Given this list of marker genes NFIL3, RAB5IF, MXRA7 (matrix remodeling associated 7), PDGFD, IRF8, ARSA, RNF8, FES, STAB2, KCTD5, LAIR2, HLA-DPB1, PSMD10, C5AR1, URGCP, PMS2P5, CEACAM7, PECAM1, VCL, DHX8, CHST15, UQCRFS1, LPCAT1, MGAM, NDUFA9, TGFBR3, TM6SF1, ACOT8, CTSO, RASL10A, UNC45A, DGKD, TMED1, GZMA, REXO4, RAB7A, ARTN (NCBI Gene Id 9048), PSTPIP1, ENPP4, CD38, TPI1, TMEM53, MAGED1, TMT1A, PHACTR4, DGLUCY, RAB38, FGD6, PTPRE, TST, MKLN1, TFF3, ADAMTS1, NFKBIL1, TMEM11, B3GAT1, GRHL2, ZNF804A, SPRED2, LAT2, ZDHHC4, CALU, ADGRA3, IFITM2, CLPB, CD8A, BLCAP, NPL, FBXO7, MAPKAPK3, TSPAN3, GALNT10, AKR1C3, CYTH4, KLRK1, PLEKHF1, MAP1S, KLHL4, LYZ, H2AC4, SUSD6, IFNA21, CEBPA, NDUFS6, RAB11FIP1, NOL10, CD63, ZNF142, PLAAT2, TTR (transthyretin), NKIRAS2, DRAM1, MOS, FEZ1, CSF1R, CAT, MT4, COQ2, ENC1, DNAI1 (NCBI Gene Id 3393), WASF2, AIF1, TARP, CRY2, JAK1, PLAC8, RNF14, TCTA, CEBPD, PLEK, ARHGAP26, PTPN12, LDLR, ZNF574, RHBDF2, NUDT11, TMEM147, THOC5, RHOQ, MRPL15, USP22, PDE7B, KIF21B, ADGRV1, AUP1, NADK, ATP1A3, ELMO1, NCR3, APOBEC3G, KLF4, RGS3, CD244, PALLD, PLCG2, PLOD1, RFTN1 (NCBI Gene Id 23180), LYN, DPY19L1, CFD, HTT, HPS1, MAPRE2, SSUH2, GFI1, MYT1L, MRM3, TLR7, FCER1G, CTSC, F2RL3, GABRD, KIR2DS2, ZNF74, CKLF, MEGF9, SPATA31F2P, TSPOAP1, NOP10, PTPN6, AGO1, NXF2, LDB2, GSN, F2R, HSPB3, TAS2R9, GFOD1, DNAJB6, AATK, MICALL1, DDAH1, NCR1, ENTREP3, MEN1, ADGRG1, ZNF484, GABRG2, APOL1, SYT11, MNDA, CCL5, SECTM1, SLCO4C1, KIR2DS1, ERMAP, CD300A, GOT1, CD302, NCAM1, CABP5, COX17, GSS, PIGO, KRT6A, PIGT, BTK, ANXA2P1, DLX5, here is a description of the gene set: species: Homo sapiens Genes down-regulated in comparison of central memory CD4 T cells versus NK cells. from publication Jeffrey KL, Brummer T, Rolph MS, Liu SM, Callejas NA, Grumont RJ, Gillieron C, Mackay F, Grey S, Camps M, Rommel C, Gerondakis SD, Mackay CR (PMID 16474395) In the present study we used Affymetrix oligonucleotide microarrays to produce gene transcription profiles for the major leukocyte types in humans. This comprehensive dataset enabled us to not only establish which genes were expressed in each leukocyte type, but also which genes were expressed in each subset after activation. The used of a comprehensive dataset of gene profiles from all the major human leukocyte subsets enabled a novel and powerful means for identification of genes associated with single leukocyte subsets, or different immune paradigms. Human Gene Set: GSE3982_CENT_MEMORY_CD4_TCELL_VS_NKCELL_DN